Given this list of marker genes SIX3, PIGN, STAT3, FGF8 (NCBI Gene Id 2253), TRIP13, UBE2T, FANCD2, SMAD4, MYH11, CARD8, PORCN, FGFR1, FANCB, FANCI, FANCA, PTCH1, STAG2, CEP57 (centrosomal protein 57), RFWD3, RARB, CDON, GLI2, CAMK2A, CDKN1A, RERE, CHST14, ZIC2, RFX6, FBN2, MEN1, PALB2, ZIC3, PLA2G4A, PLG, DYRK1A, CRIPTO, NODAL, RTTN, MAD2L2, FANCL, FANCC, CDC45, RBM10, FANCF, FOXF1, IPO8, CDKN2B, FANCE, SLX4, BRIP1, SYK, TTC7A, BRCA2, BUB1, STRA6, DLL1, WBP11, RAD51, BUB3, EP300, ACTG2, MYCN, SALL1, CENPF, XRCC2, FANCG, SUFU, WNT7B, KDM3B, GAS1, ADAM17, CHD7, RAD21, FANCM, DISP1, FLI1, CDKN2C, ARID1B, BRCA1, SHH, FOXH1, BUB1B, TGIF1, RAD51C, CDKN1B, XYLT2, ERCC4 (NCBI Gene Id 7509), CFAP45, here is a description of the gene set: An abnormality of the duodenum, i.e., the first section of the small intestine. Abnormal duodenum morphology species: Homo sapiens Human Gene Set: HP_ABNORMAL_DUODENUM_MORPHOLOGY